The following is a description of a gene set: from publication Senese S, Zaragoza K, Minardi S, Muradore I, Ronzoni S, Passafaro A, Bernard L, Draetta GF, Alcalay M, Seiser C, Chiocca S (PMID 17470557) species: Homo sapiens Genes down-regulated in U2OS cells (osteosarcoma) upon knockdown of both HDAC1 and HDAC2 by RNAi. Human Gene Set: SENESE_HDAC1_AND_HDAC2_TARGETS_DN Posttranslational modifications of core histones are central to the regulation of gene expression. Histone deacetylases (HDACs) repress transcription by deacetylating histones, and class I HDACs have a crucial role in mouse, Xenopus laevis, zebra fish, and Caenorhabditis elegans development. The role of individual class I HDACs in tumor cell proliferation was investigated using RNA interference-mediated protein knockdown. We show here that in the absence of HDAC1 cells can arrest either at the G(1) phase of the cell cycle or at the G(2)/M transition, resulting in the loss of mitotic cells, cell growth inhibition, and an increase in the percentage of apoptotic cells. On the contrary, HDAC2 knockdown showed no effect on cell proliferation unless we concurrently knocked down HDAC1. Using gene expression profiling analysis, we found that inactivation of HDAC1 affected the transcription of specific target genes involved in proliferation and apoptosis. Furthermore, HDAC2 downregulation did not cause significant changes compared to control cells, while inactivation of HDAC1, HDAC1 plus HDAC2, or HDAC3 resulted in more distinct clusters. Loss of these HDACs might impair cell cycle progression by affecting not only the transcription of specific target genes but also other biological processes. Our data support the idea that a drug targeting specific HDACs could be highly beneficial in the treatment of cancer., and this is the list of marker genes: NECTIN3-AS1, SYTL1, NUPR1, MTUS1, ATP8B1, NANOS1, ACOT2, AP1M2, CLU, BEX1, PTCH1 (NCBI Gene Id 8015), IFT74, TMEM200C, RHOBTB1, GSG1, EDN2, LSS (lanosterol synthase), ZNF219, QPRT, CSDC2, PRR16, COL1A1, TIMP3, GPC1, SPTBN1, MAP3K2-DT, FSTL1, SRD5A1, GLI2, H4C8, PCOLCE, ARID5B, DHCR7, CCSAP, TNNT2, MN1, SSBP2, DSTN, LSP1P5, KRT81, LTBP3, KRT17, TPM1, SCN2B, MAF, CXCL14, PCLO, LUM, MGST3, TENM2, TNS3, NOG (NCBI Gene Id 9241), GSTO2, ERG28, ALOX5, SYTL2, TRIB2, PDLIM1, H2AC6, MSLN, SFTA1P, MYLK, MMP24, IGFBP5, TK2, TMEM131L, PPP2R2B, MAGI2-AS3 (MAGI2 antisense RNA 3), LBH, RTKN2, SBSPON, SCARA3, NEXN, C1orf53, TUBA1A, JPH3, SPP1, IMPA2, UNKL, PKIB, KATNAL1, NACC2, HIRA, RNF187, LRP11, MYL9, CDKN2C, OLFML3, GALNT16, RIN3, GLT8D2, SLC26A2, ENSG00000310059, CAVIN2, CRIM1-DT, TMEM100, LAMB2, BNC2, MGAT5B, SERTAD4-AS1, ACADL, SYNPO, THUMPD1, ABLIM1, RHOBTB3, TUFT1, CNRIP1, ACKR3, SET, PLS3, PLAC8, IDI1, SDC1, LINC01638, MALAT1, CCL26, NTN4 (netrin 4), ANXA8, SCD, MEIS1, MYBL1, NPPB, DUSP1, MAP3K20, GXYLT2, HMGCR, FGF1, CAP2, TAGLN, PLCE1, STAC, WFDC21P, ELP4 (NCBI Gene Id 54515), WNT5A, MIR1915HG, WIPI1, COL5A2, TNS1, PDGFRL, SYT12, CDC42EP3, ABCC3, COL4A4, FGFR1, OCLN, GPX8, F8, CALB2 (calbindin 2), PSLNR, CRYAB, OCLNP1, PKP2, ATL1, ALDH3B1, LINC01270, ZNF503, LOX, COL3A1, SCEL, HAPLN1, SHOC1, GPNMB, EBF1, FADS2, FDFT1, TFPI, TCF4, S100A4, LINC01116, TMEM45A (transmembrane protein 45A), TMEM135, SQLE, SC5D, ENDOD1, CAV1, AQP1, ALPK2, DACT1, LOXL1-AS1, ZSCAN31, MFAP5, PLEKHG4, HDAC1, TCP11L1, INSIG1, NRXN3, LOXL1, EGF, KRT80, FIGN, RBMS3 (NCBI Gene Id 27303), VASN, TP53TG1, ZNF395, LAT2, TMEM255A, NFIB, DUS2, ELAPOR1, SEMA3B, DYNLL2, CALD1, COQ2, ITGBL1, DEPDC1, LOXL4, COL16A1, MSMO1, TGFB2, CELF2, PRRT3, CNN3-DT, EDIL3, KRT15 (keratin 15), PRICKLE2, NPTXR (NCBI Gene Id 23467), EPB41L3, MATN2, PLEKHH1, CADM3, C5orf46, KRT14, TNNC1, PDE1C, CCDC80, CNKSR3, ANKRD52, IGFBP7, ZNF362, H2BC5, ZNF404 (zinc finger protein 404), LRRC1, TMEM37, SESN3, DTNA, ANXA10, HDAC2, SDC2, SMAD6